The following is a description of a gene set: Reactome Pathway: Axon guidance species: Homo sapiens Axon guidance / axon pathfinding is the process by which neurons send out axons to reach the correct targets. Growing axons have a highly motile structure at the growing tip called the growth cone, which senses the guidance cues in the environment through guidance cue receptors and responds by undergoing cytoskeletal changes that determine the direction of axon growth. <br>Guidance cues present in the surrounding environment provide the necessary directional information for the trip. These extrinsic cues have been divided into attractive or repulsive signals that tell the growth cone where and where not to grow. <br>Genetic and biochemical studies have led to the identification of highly conserved families of guidance molecules and their receptors that guide axons. These include netrins, Slits, semaphorins, and ephrins, and their cognate receptors, DCC and or uncoordinated-5 (UNC5), roundabouts (Robo), neuropilin and Eph. In addition, many other classes of adhesion molecules are also used by growth cones to navigate properly which include NCAM and L1CAM.<br>For review of axon guidance, please refer to Russel and Bashaw 2018, Chedotal 2019, Suter and Jaworski 2019).<br>Axon guidance cues and their receptors are implicated in cancer progression, where they likely contribute to cell migration and angiogenesis. part of: Nervous system development, and this is the list of marker genes: SRGAP3, SCN4A, PSENEN, SCN2B, RPL8 (ribosomal protein L8), GAB2, DOK2, CLASP1, MYH10, SPTBN5, ARPC1A, PSMD8, PLXNC1, KCNQ2, GRB10, RPS3A (ribosomal protein S3A), RPL3L, RAP1GAP, SCN7A, ARHGEF28, NRP1, CHL1, FYN, RPLP0, MAPK7, GDNF, CREB1, GAB1, MAP2K1, SCN1A, RPL24, ACTR2, MYL6, NEO1, EPHA5, TLN1, PTPN11, RPL10L, RPL4, RANBP9, RPL34, EPHA8, NCAN, CD72, EPHA10 (EPH receptor A10), VAV2, RPS27A, GFRA2, AP2A2, GRIN2B, EIF4G1 (NCBI Gene Id 1981), MMP9, RPL36, UBC, SLIT1, RPL23A, ARHGEF11, SIAH1, EPHA1, PSMC2 (proteasome 26S subunit, ATPase 2), RPL27, CRMP1, CLTCL1, ANK1, UNC5D, TUBA1A, RHOA, COL4A2, TUBA1B, TUBB2B, MET, AP2A1, RPL26L1, PRKACG, SCN2A, RPL35A, CNTN6, LHX9, CACNB3, PSMB1, NCK2, HSPA8, RPS5, CDC42, AKAP5, DAB1, ADRM1, COL9A3, ITSN1, MMP2, RPSA (NCBI Gene Id 3921), EFNA5, KRAS, RELN, RASA1, ROBO1, MYL12A, SLIT3, HOXA2, GRIN1, MSI1, NRAS, MSN, ITGA2B, RPS12, PTPRA, CSNK2B, CLTC, PSMD13, EPHA3, RPL28, SOS1, DAG1, MYO9B, SEMA4A, DOK6, PAK6, MAPK1, RPL10, PFN1, UPF2, PSMA2, RPS24 (NCBI Gene Id 6229), EPHA6, ITGB1, TUBA8, SEMA3E, GFRA3, ZSWIM8, RBX1, COL9A2, UPF3A, APH1B, CNTN2, COL9A1, RPL18, ARPC4, TIAM1, RPS29, NUMB, ABL1, ROBO3, UNC5B, NCAM1, EGFR, LHX2, PPP3CB, DPYSL4, RRAS, RPL29, RPS27L, FES, PLXND1, PAK3, NELL2, RPS18, DLG1, PTPRC, VLDLR, COL3A1, DOK4, CACNB4, ROCK1, PSMB5, RPL13A, RPS11, SEMA4D, KIF4A (NCBI Gene Id 55595), ENAH, COL4A5, ITGA1, PSMD6, SEMA6A (NCBI Gene Id 57556), CXCR4, TUBB1, RPS20, LAMC1, AP2B1, TUBAL3, TRPC6, ARHGAP39, TUBB3, SH3KBP1, CASC3, CACNA1D, SOS2, RPS2, RPS25, EFNB2, SRC, PLCG1 (phospholipase C gamma 1), PIK3CD, RPS3, RPS6KA4, RPL21, RPL9, RPS15A, SPTB, ABLIM3, RDX, RPL36A, ROBO2 (NCBI Gene Id 90370), RPL22L1, EFNA3, TUBA3C, AGRN, NFASC, RPL18A, COL2A1, CAP1, DSCAM, DNM3, RET, ISL1, PSMD11, FGFR1, SRGAP1, DLG4, GAP43, RPL41, ABL2, RPS27, CD24, LAMB1, RPL12, PSMB3, EIF4A3, RPL39, CSNK2A2, EFNB3 (NCBI Gene Id 1949), RPS4X, PSMB7, CNTN1, DPYSL5, NRCAM, RPS6KA3, PIK3R3, VASP, RGMA (NCBI Gene Id 56963), PSMB4, SHTN1, RPL37A, RPS17, COL6A3, LHX3, ITGA2, LYN (LYN proto-oncogene, Src family tyrosine kinase), PFN2, APH1A, RPL6, COL5A3, PSMC1 (proteasome 26S subunit, ATPase 1), PSMD14, SLIT2, PIK3R1, CACNA1C, MAGOHB, RPS14, LHX4, RPL3, PSMD7, RPS23, SCN9A, ST8SIA4, PSMB2, TUBB4A, SCN5A, SCN10A, MAPK3, UBA52, PSMC6, ARPC1B, CACNB2 (calcium voltage-gated channel auxiliary subunit beta 2), FAU, SPTAN1, RPL36AL, CLTB, TUBB6, COL5A1, SPTBN4, PAK2, RPS7, PRKACB, WASL, RHOC, L1CAM, EPHB3, KIF4B, ITGA10, TUBB8B, DPYSL3, ARPC5, FRS2, CLASP2, PRKAR2A, NRTN, SEMA3A, ARHGEF7, NGEF, TUBB4B, RPS6KA2, RPL39L, PAK4, USP33, RPL31, RPS13, RPS6KA6, ABLIM2, GRB7, PITPNA, NTN4, SDCBP, COL6A2, TYROBP, LDB1, UNC5A, SPTBN2, COL6A5, GSK3B, RPL30, RPS16, PSMD12, RPL15 (NCBI Gene Id 6138), EFNA2, PSMD2, EPHB2, ADAM10, PTK2 (NCBI Gene Id 5747), ANK3, PSMB6, RPL10A, AP2S1, SHANK3, ABLIM1, RPS6, EFNB1, TRPC7, RGMB, SCN8A (NCBI Gene Id 6334), IRS2, DOK5, COL4A3, UBB, RAC1, GSPT1, 28S rRNA, CAP2, RPS4Y2, ARTN, EFNA4 (NCBI Gene Id 1945), SCN3B, PSMA3, EPHA4, ITGA9, SH3GL2, PRNP, SHC1, DPYSL2, PIK3R2, UPF3B, RPS6KA1, PIP5K1C, RPLP2 (NCBI Gene Id 6181), ACTR3, ARHGEF12, LAMA1, TRPC4, PSMC5, PLXNA1, SPTA1, GPC1, PLXNB3, RNPS1 (RNA binding protein with serine rich domain 1), HRAS, TRPC3, PABPC1, CLTA, NCK1, ARPC3, TUBA4A, MYH11, CDK5, RPL5, MYH9, FARP2, RPL7, PSMD3, PSMA5, UNC5C, RPL35, RPL26, SEMA6D, EFNA1, RBM8A, PRKACA, HJV, SDC2, GFRA1, COL5A2, RPS4Y1, COL4A4, RPS8, COL6A1, ROBO3.1, RPL23, PIK3CA, DOK1 (docking protein 1), ERBB2, RPL27A, AGAP2, PSEN2, ELOC, RPS10, RPS9 (ribosomal protein S9), TREM2, MYO10, ST8SIA2, ACTB, SEMA7A, PSMA7, SHC3, GFRA4, PSPN, PSMA4, ITGB3, PIK3CB, RPLP1, RPL38, RPL17, PSMD1, PLXNB1, CACNA1I, SEMA5A, TRPC5, NCBP2, KCNQ3, RPS26, ARPC2, CACNB1, RPL14, PSMA6, 18S rRNA, PAK1, RPL19, DNM2, RPL7A, ANK2 (ankyrin 2), PRKCQ, LIMK1 (NCBI Gene Id 3984), TUBA1C, AP2M1, VAV3, ARHGAP35 (NCBI Gene Id 79266), EPHB1, CSNK2A1, PLXNA3, CACNA1S, ITGAV, MAGOH, PLXNA4, SCN11A, DNM1, PDLIM7, TUBA3E, RPS19, CFL1, CACNA1H, HSP90AA1, EPHA7, NCSTN, CACNA1G, RPL13, CXCL12, RPS21, DOCK1, DLG3, ETF1, 5.8S rRNA, TUBB2A, PLXNA2, DCC, CDK5R1, SCN4B, EVL, TUBA3D, MAP2K2, GSPT2, GRB2 (NCBI Gene Id 80715), ELOB, RPL37, HSP90AB1, PSMC3, MYL9, SPTBN1, EZR, NTN1, CNTNAP1, RPL32, SCN1B, NRP2, ROCK2 (NCBI Gene Id 9475), MYL12B, MYH14, RPL22, SIAH2, RND1, TRIO, DSCAML1, PSEN1, RPS28, PRKCA, YES1 (YES proto-oncogene 1, Src family tyrosine kinase), EPHB6, ACTG1 (actin gamma 1), COL4A1, CUL2, ALCAM, SEM1, COL6A6, EPHA2, KALRN, RPL11, TUBB8, LIMK2, PAK5, FLRT3, EPHB4, RHOB, SCN3A, ITGA5, RPS15, SRGAP2, RPS6KA5 (NCBI Gene Id 9252), LYPLA2, PSMA1, NCBP1, PSMC4, DCX, TUBA4B, 5S rRNA, GIT1, TRPC1